The following is a description of a gene set: Reactome Pathway: Signal transduction by L1 part of: L1CAM interactions studied in species Homo sapiens Besides adhesive roles in cell cell interaction, L1 functions as a signal transducing receptor providing neurons with cues from their environment for axonal growth and guidance. L1 associates with beta1 integrins on the cell surface to induce a signaling pathway involving sequential activation of pp60csrc, Vav2 -GEF, Rac1, PAK1, MEK and ERK1/2. L1 stimulates cell migration and neurite outgrowth through the MAP kinases ERK1/2. CHL1 also associates with integrins and activates a MAPK signaling pathway via pp60c-src, MEK and ERK1/2. <br>L1 also binds the Sema3A receptor neuropilin1 and acts as an obligate coreceptor to mediate Sema3A induced growth cone collapse and axon repulsion. This repulsion can be converted to attraction by homophilic binding of L1 on an apposing cell in trans with L1 complexed with Neuropilin1 (NP1) in the responding neuron.<br>L1 also interacts with FGF receptor and activates PLC gamma and DAG, resulting in the production of arachidonic acid and subsequent opening of voltage-gated channels., and this is the list of marker genes: VAV2, MAPK3, CSNK2B, ITGB1, L1CAM, ITGA2B, RAC1, ITGB3, ITGA9, FGFR1, PAK1, CSNK2A1, EGFR, MAP2K2, NCAM1, ITGAV, NRP1, CSNK2A2, MAP2K1, ITGA5, MAPK1